The following is a description of a gene set: The chemical reactions and pathways involving glucosylceramides, any compound formed by the replacement of the glycosidic hydroxyl group of a cyclic form of glucose by a ceramide group. They are neutral glycolipids containing equimolar amounts of fatty acid, glucose, and sphingosine or a sphingosine derivative. studied in species Mus musculus Mouse Gene Set: GOBP_GLUCOSYLCERAMIDE_METABOLIC_PROCESS, and this is the list of marker genes: Gba2, Fa2h, Prkcd (NCBI Gene Id 52581), Ugcg, Psap, Gba1